Given this list of marker genes Lats1, Fgfr1, Abl1, Crk, Zdhhc12, Gap43, Abi3, Slitrk3, Nlgn1, Lrrtm1, Ptk2b, Ntrk3, Arhgef9, C1ql3, Nptxr, Ntng2, Dock7, Cript, Ptprs, Shank3, Nrxn1, Lrfn4, Lrrc4b, Lrfn1, Nrxn3, Ptprd, Abi3bp, Crkl, Prickle1, Nlgn3, Pten, Grid2, Reln, Wnt5a, Prickle2, Sptbn2, C1ql2, Csmd2, Il1rap, Nptx1, Nrxn2, Nlgn2, Cbln1, Sipa1l1, Caskin1, Lrrtm2, here is a description of the gene set: The aggregation, arrangement and bonding together of a set of components to form a postsynaptic specialization, a region that lies adjacent to the cytoplasmic face of the postsynaptic membrane. Mouse Gene Set: GOBP_POSTSYNAPTIC_SPECIALIZATION_ASSEMBLY species: Mus musculus